Given this list of marker genes TNFSF10, RIPK1, BIRC3, STUB1, UBB, CASP8, PELI1, FLOT1, BIRC2, UBC, MLKL, TNFRSF10A, RIR1, FADD, FLOT2, UBA52, UBE2L3, HSP90AA1, PDCD6IP, RIPK3, NS, TRAF2, FAS, CDC37, ITCH, OGT, FASLG, XIAP, CFLAR, TRADD, SDCBP, TNFRSF10B, RPS27A, PRKN, here is a description of the gene set: Receptor-interacting serine/threonine-kinase protein 1 (RIPK1) and RIPK3-dependent necrosis is called necroptosis or programmed necrosis. The kinase activities of RIPK1 and RIPK3 are essential for the necroptotic cell death in human, mouse cell lines and genetic mice models (Cho YS et al. 2009; He S et al. 2009, 2011; Zhang DW et al. 2009; McQuade T et al. 2013; Newton et al. 2014). The initiation of necroptosis can be stimulated by the same death ligands that activate extrinsic apoptotic signaling pathway, such as tumor necrosis factor (TNF) alpha, Fas ligand (FasL), and TRAIL (TNF-related apoptosis-inducing ligand) or toll like receptors 3 and 4 ligands (Holler N et al. 2000; He S et al. 2009; Feoktistova M et al. 2011; Voigt S et al. 2014). In contrast to apoptosis, necroptosis represents a form of cell death that is optimally induced when caspases are inhibited (Holler N et al. 2000; Hopkins-Donaldson S et al. 2000; Sawai H 2014). Specific inhibitors of caspase-independent necrosis, necrostatins, have recently been identified (Degterev A et al. 2005, 2008). Necrostatins have been shown to inhibit the kinase activity of RIPK1 (Degterev A et al. 2008). Importantly, cell death of apoptotic morphology can be shifted to a necrotic phenotype when caspase 8 activity is compromised, otherwise active caspase 8 blocks necroptosis by the proteolytic cleavage of RIPK1 and RIPK3 (Kalai M et al. 2002; Degterev A et al. 2008; Lin Y et al. 1999; Feng S et al. 2007). When caspase activity is inhibited under certain pathophysiological conditions or by pharmacological agents, deubiquitinated RIPK1 is engaged in physical and functional interactions with the cognate kinase RIPK3 leading to formation of necrosome, a necroptosis-inducing complex consisting of RIPK1 and RIPK3 (Sawai H 2013; Moquin DM et al. 2013; Kalai M et al. 2002; Cho YS et al. 2009, He S et al. 2009, Zhang DW et al. 2009). Within the necrosome RIPK1 and RIPK3 bind to each other through their RIP homotypic interaction motif (RHIM) domains. The RHIMs can facilitate RIPK1:RIPK3 oligomerization, allowing them to form amyloid-like fibrillar structures (Li J et al. 2012; Mompean M et al. 2018). RIPK3 in turn interacts with mixed lineage kinase domain-like protein (MLKL) (Sun L et al. 2012; Zhao J et al. 2012; Murphy JM et al. 2013; Chen W et al. 2013). The precise mechanism of MLKL activation by RIPK3 is incompletely understood and may vary across species (Davies KA et al. 2020). Mouse MLKL activation relies on transient engagement of RIPK3 to facilitate phosphorylation of the pseudokinase domain (Murphy JM et al. 2013; Petrie EJ et al. 2019a), while it appears that stable recruitment of human MLKL by necrosomal RIPK3 is an additional crucial step in human MLKL activation (Davies KA et al. 2018; Petrie EJ et al. 2018, 2019b). RIPK3-mediated phosphorylation is thought to initiate MLKL oligomerization, membrane translocation and membrane disruption (Sun L et al. 2012; Wang H et al. 2014; Petrie EJ et al. 2020; Samson AL et al. 2020). Studies in human cell lines suggest that upon induction of necroptosis MLKL shifts to the plasma membrane and membranous organelles such as mitochondria, lysosome, endosome and ER (Wang H et al. 2014), but it is trafficking via a Golgi-microtubule-actin-dependent mechanism that facilitates plasma membrane translocation, where membrane disruption causes death (Samson AL et al. 2020). The mechanisms of necroptosis regulation and execution downstream of MLKL remain elusive. The precise oligomeric form of MLKL that mediates plasma membrane disruption has been highly debated (Cai Z et al. 2014; Chen X et al. 2014; Dondelinger Y et al. 2014; Wang H et al. 2014; Petrie EJ et al. 2017, 2018; Samson AL et al. 2020 ). However, microscopy data revealed that MLKL assembles into higher molecular weight species upon cytoplasmic necrosomes within human cells, and upon phosphorylation by RIPK3, MLKL is trafficked to the plasma membrane (Samson AL et al. 2020). At the plasma membrane, phospho-MLKL forms heterogeneous higher order assemblies, which are thought to permeabilize cells, leading to release of DAMPs to invoke inflammatory responses. MLKL also exerts non-necroptotic functions such as regulation of endosomal trafficking or MLKL-induced activation of the NLRP3 inflammasome (Yoon S et al. 2017; Shlomovitz I et al. 2020; Yoon S et al. 2022). While RIPK1, RIPK3 and MLKL are the core signaling components in the necroptosis pathway, many additional molecules have been proposed to positively and negatively tune the signaling pathway. Reactome Pathway: RIPK1-mediated regulated necrosis part of: Regulated Necrosis species: Homo sapiens